The following is a description of a gene set: The process in which a relatively unspecialized cell acquires specialized features of a muscle cell. species: Homo sapiens Human Gene Set: GOBP_MUSCLE_CELL_DIFFERENTIATION, and this is the list of marker genes: LAMB1, WNT5B, NPHS1, CACNA1S, NOTCH4, ANKRD23, DOCK1, ACTN1, CXADR, P2RX2, B4GALNT2, RGS2, CAMK1, LRRC10, CCNB1, PRICKLE1, ARRB2, MYOM2, MYL2, KLHL41, CNTNAP1, PRKD1, NRG1, MIR499A, ACTN4, GSK3A (glycogen synthase kinase 3 alpha), SELENON, MYO18B, SOX6, MIR199B, CEACAM5, ITGA8, MEF2A, YY1, C10orf71, CDON, TANC1, SRF, MAPK11 (mitogen-activated protein kinase 11), MYH11, TNFSF14, AKAP13, MECP2, EHD1, RGS4, PAK1, NPNT (NCBI Gene Id 255743), IGF2, EFNB2, DYRK1B, MYBPC1, SMAD4, MIR22, VEGFA, MIR21, MYORG, YBX1, SKI, TBX18, FOXF1, KCNH1, FGF10, MYPN (NCBI Gene Id 84665), MIR15B, RBM4, ADAMTS5, EFEMP2, CALR, CBY1, HIRA, PIEZO1, WDR1, KRAS, RB1, CCL8, MYC, FHOD3, ALPK3, PTBP1, FGF9, BDNF, NKX2-5, CHUK, MYMX, CYP26B1, ACTA1, HDAC9, ACTC1, RBPMS2 (NCBI Gene Id 348093), SIX4, CACNA2D2, GATA6, ADPRHL1, TNNT3, NACA, FZD7, STAC3, MYH6, FKRP, MESP1 (mesoderm posterior bHLH transcription factor 1), IGF1 (insulin like growth factor 1), ANKRD1, LAMB2 (NCBI Gene Id 3913), SYNPO2L, XK, MIR100, COMP, ASF1A, OR10J5, CDH2, HOPX, EREG, DUSP29, BCL9 (BCL9 transcription coactivator), KCNJ8, DMD, MYBPC2, ADM, KDM6B, ANHX, SMARCD3, CCN3, NFATC1 (nuclear factor of activated T cells 1), CTDP1, LAMA1, WFIKKN2, MTLN, MIR199A1, BIN3, OLFM2, BMPR1A, KAT2A, PDGFRA, SIRT1, SMYD1, FKTN, MYBPC3, ENG, TSC1 (TSC complex subunit 1), AVPR1A, LAMA2, ALPK2, PIAS1, PRKAR1A, EDNRA, MIR140, AKIRIN2, MYOG, RCAN1, KRT19, OBSCN, BHLHA15, PTGFRN, SIX1, MRTFA, GPX1 (NCBI Gene Id 2876), SMAD1, WT1, CASQ1, MEIS1, MYOZ1, PLEKHO1, CXCL10, TRIM72, IFRD1, FOXO4, KLF5, EZH2, AFG3L2, NEB, HNRNPU, DKK1, HES1 (hes family bHLH transcription factor 1), MTOR, ADAM12, MIR26A1, COL14A1 (collagen type XIV alpha 1 chain), FRS2, RXRB, HEY2, PTCD2, KDM1A, TBX2, CD81, POPDC2, TRIM32, IL4R, NOTCH1, GLMN, FBXO40, MRTFB, MYH3, ACTN3, CFL2, SYNE1, GDF15, NFATC3, DLL1, RARB, MIR200B, BARX2, TBX3, ISL1, TOMM70, TMOD2, ZNHIT1, TBX1, NFATC4, LMNA, TPM1, CAV3, WNT10B, CACYBP, FHL2, BVES, G6PD, PI16, RARA (retinoic acid receptor alpha), PROX1, TNNT1, PLD3, CAPN2, NAGLU, MYLK3, SMO, HDAC3, SGCB, TARBP2, MYOD1, NLN, H3-3B, RYR1, BHLHE41, RAMP2, MIR221, SYPL2, CSRP2, PDCD4, NID1, TNNT2, MIR19A, SCGB3A1, SDC1, POPDC3, MSX1, MEF2C (myocyte enhancer factor 2C), EDNRB, ZEB1, SHOX2, SMYD3, TMOD4, TGFB1, MIR19B1, MYF5, CSRP3, ATP2A2, NEO1, IRX3, FLOT1, PDGFRB, CHRNB1, LAMC1, KEL, MIR1-1, LBX2, HDAC5, DNMT1, KIT, FGFR2, MYH10 (NCBI Gene Id 4628), CASP7 (caspase 7), MIR208A (microRNA 208a), ERVFRD-1, MAPK12, MYMK, GATA4, TCF23, PLEC, ATG5, ADGRB3, MIR195, BCL2, EDN1 (NCBI Gene Id 1906), DMPK, SHH (sonic hedgehog signaling molecule), TMEM182, MAML1, ADAMTS15, MIR145, ASB2, NINJ1, BMP4, BMPR2, EHD2, SIRT6, MIR23A, MYEF2, RIPOR2, ACADM, AKAP6, PITX2, MIR133B, ZBED6 (zinc finger BED-type containing 6), SPG11, IGFBP5, PLPP7, CTCF, TMEM119, MIR204, PPARA, MIR125B1, PGM5, SETD3, MED28, CTNNB1, HDGFL2, APLNR, OBSL1, FOXP1 (forkhead box P1), SGCZ, TNPO2, MIR24-1, TBX5, LMOD1, WNT3A, LDB3, XBP1, BNIP2, ERVW-1, AKT1, NRAP, SEMA4C, MAMSTR, CD53, QKI, UCHL1, ADGRB1, MYOM1, CDK1, RBM24, ACTG1, FLNC, SUPT6H, MYOZ2, PRKG1, RORA, MYL9, MEGF10 (multiple EGF like domains 10), CCNT2, SLC8A1, IFT20, MMP14, CAPN3, ATP11A, NEBL, MIR590, LARGE1, ANK2, RPL3L, BMP10, SPAG9 (sperm associated antigen 9), CTH, ID2, DOCK2, MIR222, NOS1, MDM2, CD9 (NCBI Gene Id 928), MYF6, CXCL9, RBM38, PPP3CB, WFIKKN1, LMOD3, NPPA, MYBPH, WNT4, CDK9, MAPK14, PDLIM5, BMP2, LOX, TMEM204 (NCBI Gene Id 79652), NOX4, SOD2, MIR133A1, ZMPSTE24, NKX2-6, MIR34A, SLC9A1, NOTCH2, TMOD3, ACTN2, CACNA1H, PARP2, GPER1, DNER, CFLAR, TTN, FBXO22, HDAC4, TCAP, HOMER1, MYH9 (NCBI Gene Id 65212), MIR206, FLII, DCAF8, PPP3CA, GREM1, MIR18A, COL6A1, TMOD1, MYOM3, SORBS2, H3-3A, MIR424, SORT1, WNT1, KLHL40, BIN1, LMOD2, ADRA1A, NFATC2, CAV2 (caveolin 2), SIK1, ACVR1, PRDM6, SGCD, PPIF, CSRP1, MYOCD, GREB1L, HDAC1, PDGFB, CACNB4, HEY1, SOX9, CASP3, SPEG, DOCK5, ITGB1